Given this list of marker genes Ptger2, Ccr2, Hcst, Hif1a, Fgl1, Trp53, Stag1, Muc1, Il6ra, Anxa1, Apc, Pgf, Dot1l, Gpr4, Lag3, Arhgef4, Ptch1, Cdk1, Nrp1, Id1, Ptk2, Gzmb, Ralgds (ral guanine nucleotide dissociation stimulator), Arl6ip5, Adam9, Il12rb2, Myct1, Mmp2, Rhoj, Setd4, Cybb, Pld1, Nup85, Rcan1, Skil, Ets2 (NCBI Gene Id 23872), Gpnmb, Cdc20, Cd151, Antxr1, Dnajc27, Fbln5, Jcad, H2ax, Cd44, Fos, Gpr68, Igf1 (NCBI Gene Id 320499), Cd248, Adam15, Cav2, Idh2, Mmp1a, Loxl2, Msi2, Fzr1, Pdcd1, Ptger1, Cxcr2, Slc3a2, Pard3, Trim27, Il1b, Mgat5, Kras, Plg, Kit, Ccm2l, Ptp4a3 (NCBI Gene Id 19245), Rbpj, Plau, here is a description of the gene set: species: Mus musculus from publication Motenko H, Neuhauser SB, O'Keefe M, Richardson JE (PMID 26092688) Mouse genes annotated to decreased tumor growth/size (MP:0003447) retrieved from the Mouse Genome Informatics database via MouseMine Mouse Gene Set: MP_DECREASED_TUMOR_GROWTH_SIZE